Given this list of marker genes Stxbp1, Unc13b, Snap29, Prrt2, Cplx4, Syt1, Syt3, Stxbp3, Cplx3, Vps11, Baiap3, Rab4a, Ptpn2, Syt2, Tmed10-ps, Tmed9, Vps52, Stxbp4, Txlnb, Gopc, Abl1, Vamp2, Vps54, Hectd3, Stxbp2, Cplx1, Nsf, Unc13c (unc-13 homolog C), Vps18, Cav1, Vamp3, Stx8, Septin5, Cacna1a, Napa, Syt4, Scfd1, Syp, Vamp8, Snap25, Stx16, Sec22b, Syt5, Txlna, Syt6, Napb, Txlng (NCBI Gene Id 353170), Slc6a4, Myo5a, Golga2, Unc13a, Bet1, Cplx2, Vamp1, Abcc9, Tmed10, Rnf40, Cav2, Tpcn1, Stx6, Stx7 (syntaxin 7), Snap23, Syt7, Napg, Dapk1, Doc2b, Lrrk2, Stxbp5, Stxbp5l, Snap47, Abca1, here is a description of the gene set: Mouse Gene Set: GOMF_SYNTAXIN_BINDING studied in species Mus musculus Binding to a syntaxin, a SNAP receptor involved in the docking of synaptic vesicles at the presynaptic zone of a synapse.